Given this list of marker genes USP17L2, GZMA, TMED2, SERPINA5, URI1, ECM1, SH3BP4, FETUB, PLXNB3, NEIL1, KLRK1, RECK, SERPINB3, GPSM1, CRB2, GAPDH, RRP1B, EPPIN, SERPINB9, CHP1, ATP5IF1, SERPINB4, CR1, TIMP1, SPOCK3, RDX, ARL2, SPOCK2, TIMP2, DAB2IP (DAB2 interacting protein), RCC2, LRCH1, EPM2A, SERPINB8, ABCE1, GNAT1, PLIN5, LRRK2, SERPINB13, RASA4, DFFA, UBXN1, CAMK2A, SERPINB1, KLRC4-KLRK1, ARFGEF1 (NCBI Gene Id 25860), MIR138-1, FICD, here is a description of the gene set: studied in species Homo sapiens Human Gene Set: GOBP_NEGATIVE_REGULATION_OF_HYDROLASE_ACTIVITY Any process that stops or reduces the rate of hydrolase activity, the catalysis of the hydrolysis of various bonds.